Given this list of marker genes Gp1bb, Col1a2, Gp9, Gp1ba, here is a description of the gene set: part of: Platelet activation, signaling and aggregation This event has been computationally inferred from an event that has been demonstrated in another species.<p>The inference is based on the homology mapping from PANTHER. Briefly, reactions for which all involved PhysicalEntities (in input, output and catalyst) have a mapped orthologue/paralogue (for complexes at least 75% of components must have a mapping) are inferred to the other species. electronically inferred by orthology from the curated human pathway Reactome Pathway: GP1b-IX-V activation signalling species: Mus musculus